The following is a description of a gene set: Genes predicted to be targets of miRBase v22 microRNA mmu_miR_6371 in miRDB v6.0 with MirTarget v4 prediction scores > 80 (high confidence targets). species: Mus musculus from publication Chen Y, Wang X (PMID 31504780) Mouse Gene Set: MIR_6371, and this is the list of marker genes: Trpc3, Mab21l1, Vdac1 (NCBI Gene Id 22333), Mex3c (NCBI Gene Id 399620), Tub, Fsd1l, Hyls1, Bag4, Nab1, Rgs17, Dcaf7, BC051019, Cdk8, Arpp21, Ugt8a, Sh3rf1 (NCBI Gene Id 97498), Pphln1, Ypel1, Acsl3, Ddit4, Uqcrc2, Sar1b, Adamts17, Ube2e2, Slitrk5, Chd2, Chrdl1, Grhl3, Eif1b, Tesk2, Mxi1, Esrp1 (NCBI Gene Id 70076), E2f7, Clic5, Adgrl1, Phf3, Slc25a20, Senp5, Mtx2, Kcnj2, Nabp1 (nucleic acid binding protein 1), Zbtb7c, Cebpz, Septin6, Lsm12, Otud4, Pfdn4, Cd24a, Vmn2r28, Cpeb2, Vamp4, Ppip5k2, Strbp, Sema6d, Apcdd1, Itfg1, Slc45a4, Foxk2, Greb1l, Chfr, Armcx2 (NCBI Gene Id 67416), Cyp11a1, Col27a1, Appl2, Il6, Trib2, Map3k9, Map3k13 (NCBI Gene Id 71751), Erap1, Tnrc6b, Zfp518a, Dnajc21, Atp6v0e, Mef2c, Epb41l3, Dmrt3, Pon3, Dab2, Syde2, Atrx, Arhgef26, Fbxo11, Gm16405, Matr3, Rwdd4a, Arhgap21, Zdhhc20, Onecut2, Zfp275, Cped1, Mllt6, Alg5, Hoxd13, Osbpl11, Magi3, Chic1, Cttnbp2nl, Bicd2, Bcl11a, Capn10, Ubn2, Tnks1bp1, Tdrd7, Aldh5a1, Stradb (NCBI Gene Id 28142), Slxl1, Slc44a2, Mfsd14a, Fgd1, Shisa5, Adam17, Etf1, Klhl18, Zfp799, Zfp236, Cd46, Nagpa, Galnt7, Snx30, Ghsr, Mapk6, Mtdh, Nsd2, Prr5l, Fbxo28, Adam23, Trp53inp1, Acsl4, Mex3b, Jag1, Zfc3h1, Eif4enif1, Zbtb24, Kctd18, Mycbp, Ryk, Skp2, Plcb1, Ccnjl, Sdf2, Zbtb21, Fam227a, Ankrd52, Ssh2, Tmem248, Ep300, Cyp2j6, Abhd5, Scai, Kazn, Serpini1, Kpna2, Prph2, Tmc7, Fut9, Chordc1, Dennd1b, Fam98a, Sptbn1, Cd59b, Stac2, Phf20l1, Deup1, Sostdc1, Tcf12, Adamts19, Ddx3x, Larp1, Mitf, Ppp1r15b, Mfsd6, Cdr2 (cerebellar degeneration-related 2), Gpr50, Trim33, Abcb7, Pgrmc2, Bak1 (BCL2-antagonist/killer 1), Camsap1, Taf5, Suz12, Dyrk1a, Aldh1b1, Tet1, Dcun1d2 (NCBI Gene Id 234073), Sox5 (NCBI Gene Id 319649), Kcne4, Dst, Ero1b, Dctn4, Gpr34, Tppp, Pcnx1, Ark2n, Bcr, Epc1, Ccl3, Aste1, Pdcd10, Ulk1, Lss, Cdr2l, Tbc1d4, Kmt5a, Tbl1xr1, Epc2, Rps6ka6, Hoxd8, Smap2, Casz1, Tfap2a, Anks1, Cnot6l, Itpr1, Tmem135, Sall3, Dcdc2a, Ccn2, Col22a1, Tet2, Dnmt3b, Cdk6, Stk39, Ice1, Gmds, Gm16430, Itprid2, Dusp6, Asxl1, Slf2, Nap1l5, Cyrib, Pcgf3, Cpeb3, Psd3, Mal2, Btg1, Cep350, Slc26a9, Klhl42, Clvs2, Hspa4l, Nup50, Tnrc6c, Zfp800 (zinc finger protein 800), Palm3, Pik3r3 (phosphoinositide-3-kinase regulatory subunit 3), Hipk1, Lef1, Rab11a, Hebp2, Rassf3, Chd1, Sh3d19, Adamts18, Unc50, Tmem263, Zdhhc6, Scn2a, Lin28b, Pigm, Cacna1c, Birc5, Zfp462 (zinc finger protein 462), Bicral, Camsap2, Ccnj